The following is a description of a gene set: species: Homo sapiens Any process that results in a change in state or activity of a cell or an organism (in terms of movement, secretion, enzyme production, gene expression, etc.) as a result of an ethanol stimulus. Human Gene Set: GOBP_RESPONSE_TO_ETHANOL, and this is the list of marker genes: TNFRSF11A, POLB, GLRA2, GRIN2A, MT-ND4, CSF3, GABBR1, ADIPOQ, S100A8, SOD1, KCNC2, HMGCS2, LEP, USP46, NPPC, SDF4, CYP7A1, DRD3 (dopamine receptor D3), PRKCE, CD27, SPI1 (Spi-1 proto-oncogene), FOS, OPRK1, CDO1, MT-CYB, FGF2, CDK1, GNRH1, NR0B2, TP53INP1, CLDN3, TBXAS1, PPARA, BIRC2, CYBB, G6PD (NCBI Gene Id 83159), TACR1, BAK1, CBL, DNMT3A, ATP5F1A, HPGD, TH (tyrosine hydroxylase), MSTN, FECH, ELK1, SLC23A2, GRIA1, RPS6, ADCYAP1R1 (NCBI Gene Id 117), RGS2, CLDN18, CREB1, ACTC1, FGFR2, GRIN2B, RPL10A, SETD7, MYD88, CAT, PENK, PTH, CRHR1 (corticotropin releasing hormone receptor 1), HDAC2, SOD2, CASP8, CCL7, NTRK3, ADH7, ALAS1, DBH, EPS8, OPRM1, CA3, RELA, RARA, EEF2, CD4, OPRD1, FYN, IL13, SLC2A4, CRHBP (corticotropin releasing hormone binding protein), VCAM1, CLDN1, CD68, CRH, GRIN1, EEF1B2, PRKCA, SLC10A1, AVP, FOSB, CHRNB2, DRD4 (NCBI Gene Id 1815), CLDN5, GRIN3A, STAT3, PSMD14, GATA3, RGS4 (NCBI Gene Id 5999), CCND1, OXCT1, TGFB1 (transforming growth factor beta 1), PRKAA1, ADCY7, GSTP1, SLC6A3, IL2, CPT1A, TNC, DMAP1, TNF, RBP4, BGLAP, ABAT, DRD2, GLRA1, TBXA2R, FGF19, SREBF1 (NCBI Gene Id 6720), ALAD, ITPR2, GOT2